Given this list of marker genes XXYLT1, TOX, IFITM3, LGALS1, CSRP2, PLSCR1, USP27X, MGAT5, MAGED2, NUDT4, H2AZ1, ITGAE, ANXA2, P4HA1 (NCBI Gene Id 5033, prolyl 4-hydroxylase subunit alpha 1), EEA1, MAP7, SAMD11, RORC, NT5E, MAF, TMEM65, CPD (NCBI Gene Id 1362), TJP2 (NCBI Gene Id 9414), AVEN, MBNL3, SLC4A7, GATA1, CEBPA, MLF2, IFITM2, MAP3K8, ATP6V0D2, CCR2, BATF, ADAM17, INPP5F, CCR4, SOCS2, CD83, RRAGD, IKZF4, ADSS2, GSAP, PAFAH1B3, CYTH3, HDAC6, GPLD1, CCDC157, PHLPP1, SWAP70, RALGDS, RNF216, ENTPD1 (ectonucleoside triphosphate diphosphohydrolase 1), IZUMO1R, SDCBP2, IRAK2, FAM241B, PEAR1, SLAMF1, SNX14, ADAP1, TP53INP1, S100A10, AHNAK, IKZF3 (IKAROS family zinc finger 3), MYO1C, TNFSF11, CD200, DCTN4, ACOT9, EMC3, CD6, KY (kyphoscoliosis peptidase), BCL2L1, ADCK5, ARHGAP17, LAMC1, SCN11A (NCBI Gene Id 337933), KLRG1, VPS54, LCLAT1, GSTO1, DND1, ARHGAP21, DNAH7, TNFRSF18, IL2RA, GFI1, GNA12, ICAM1, ACSBG1, SPRED1, GRIK5, PRG4, CC2D2A, NRN1, SLC22A5, MAP3K5, SAMHD1, CAPG, RAPGEF5, CD81, IGF1R, ICOS, RFK, GPR83, IFT80, CDK17, HEPACAM2, WDFY2, DENND5A, CCR6, PPM1L, NOD1, RNF215, TNK2, SLC9B2, CCN4, PHTF2, TSPAN3, SAPCD1, SOCS5 (NCBI Gene Id 9655), AHCYL2, SAV1, ALCAM, IKZF2, FRMD6, YBX3, NIBAN1, KAT2B, KIAA1958, LRRC8D, UNC119, ITIH5, CLIP3, SLC2A3, CAPN3, GADD45G, ZDHHC2, RECK, SH3RF1, B3GNT2, DSTN, TMBIM1, PRKCH, PLP2, TYMS, REEP3, ZBTB32, ABHD4, ZNF23, LXN, LAD1, SYTL1, TWSG1, TBCB, NPAS4, ABHD17C, SUPT4H1, ENO3, SMC4, ZNF608, KIAA1191, STON1, JAK3, ZCCHC18, EBI3, IFT46, KIF3B, HIP1R, DLG1, ZDHHC23, OAZ2, GUCY1A1, NTN1, SYPL1, GBP4, ARRDC4, LONRF1, PRNP, MCUB, PHACTR2, HOMER1, SAMSN1, EPHX1, CHST2, RAB8B, S100A6, S100A4, LGALS3, IL1RL1, CISH (NCBI Gene Id 29917), SLC41A1, CHCHD10, AOPEP, GPR160, XBP1, MYO1E, BCL2A1, ARHGEF12, here is a description of the gene set: Genes down-regulated in the mature neuron cell line: control versus infected with western equine encephalitis virus. Human neuronal differentiation alters responsiveness to innate immune stimuli and virus infections. We used microarrays to examine the transcriptional responses of the human BE(2)-C neuroblastoma cell line to infection with western equine encephalitis virus (WEEV). Human Gene Set: GSE16451_CTRL_VS_WEST_EQUINE_ENC_VIRUS_MATURE_NEURON_CELL_LINE_DN from publication Peltier DC, Simms A, Farmer JR, Miller DJ (PMID 20483728) studied in species Homo sapiens